Given this list of marker genes ATP6V1B1, ATP6V0A4, NHERF1 (NHERF family PDZ scaffold protein 1), AGT, SLC22A6, CHRNA7, CORIN, STC1, SCN11A, NPSR1, SPX, TACR1, MLLT6, LIPA, SLC22A12, COMT, AGTR1, DRD2, UMOD, NPPB, MDK (midkine), EDN1, CHRNB4, CHRNB2, CLN3, ABCG2, EDNRB, TRPV1, CHRNA3, NPR1, KCNMA1, here is a description of the gene set: Human Gene Set: GOBP_EXCRETION The elimination by an organism of the waste products that arise as a result of metabolic activity. These products include water, carbon dioxide (CO2), and nitrogenous compounds. studied in species Homo sapiens